The following is a description of a gene set: studied in species Mus musculus Mouse Gene Set: GOBP_LIPID_IMPORT_INTO_CELL The directed movement of a lipid from outside of a cell into a cell. This may occur via transport across the plasma membrane or via endocytosis., and this is the list of marker genes: Stra6, Slc27a5, Lipa, Eprs1, Irs2, Rbp4, Slc27a2, Cd36, Akt2, Stra6l, Fabp3, Slc27a1, Rps6kb1, Spx, Slc27a4, Acsl1 (acyl-CoA synthetase long-chain family member 1), Slc27a6, Plppr4, Slc2a1, Akt1, Thbs1, Abcc1, Acsl6, Acsl3, Acsl5